Given this list of marker genes Trex1, Btk, Sting1, Aars2 (alanyl-tRNA synthetase 2, mitochondrial), Tab1, Spsb3, Aurkb, Cgas, Banf1, Zdhhc9 (zinc finger, DHHC domain containing 9), Pcbp2, Ppp6c, Smpdl3a, Slc19a1, Irgm1, Lyplal1, Igtp, Zdhhc18, Akt1, Parp1, Map3k7, Prkdc, Irgm2, here is a description of the gene set: The series of molecular signals initiated by the binding of a double-stranded DNA or RNA from another organism to cytosolic cyclic GMP-AMP (cGAMP) synthase (cGAS) that activates innate immune responses through production of the second messenger cGAMP, which activates the adaptor STING. Mouse Gene Set: GOBP_CGAS_STING_SIGNALING_PATHWAY species: Mus musculus